The following is a description of a gene set: species: Homo sapiens Human Gene Set: GOBP_REGULATION_OF_ENDOTHELIAL_CELL_DIFFERENTIATION Any process that modulates the frequency, rate or extent of endothelial cell differentiation., and this is the list of marker genes: VEGFA, BMP4, ADD1, CEACAM1, ROCK1, F11R, NOTCH4, MIR10A, TNF, APOLD1, ROCK2, DSG2, CLDN5, S1PR3, MIR150, S1PR2, GDF2 (growth differentiation factor 2), PROC, ZDHHC21, PLCB1, VEZF1, ZEB1, BMP6, JAG1 (jagged canonical Notch ligand 1), VCL, ACVRL1, MIR21, MIR1-1, CTNNB1, FOXJ2, PPP1R12A, ETV2, BTG1, MIR99B, IL1B, MIR34A, MIR199B, ATOH8, MIR495, NOTCH1, TMEM100, CDH5, MIR200C, MIR181A2, IKBKB, MIR181B1, TNFRSF1A